The following is a description of a gene set: Human Gene Set: GOMF_SIALIC_ACID_BINDING Binding to a sialic acid, a N- or O- substituted derivative of neuraminic acid, a nine carbon monosaccharide. Sialic acids often occur in polysaccharides, glycoproteins, and glycolipids in animals and bacteria. studied in species Homo sapiens, and this is the list of marker genes: ST8SIA3, SIGLEC10, SIGLEC11, SIGLEC9, FCN1, SIGLEC16, ADIPOQ (NCBI Gene Id 9370), MAG, SELL, AGRN, SELP, SIGLEC5, SELE (selectin E), SIGLEC12, CD33, ST8SIA4, SIGLEC14, SIGLEC6, ST8SIA2, CD22, SIGLEC8, SIGLEC7